The following is a description of a gene set: Human Gene Set: GOCC_CYTOPLASMIC_MICROTUBULE studied in species Homo sapiens Any microtubule in the cytoplasm of a cell., and this is the list of marker genes: CFAP52, ENKD1, TMEM214, CYP2A6, CYLD, RIBC1, TRPV4, PACRG, CFAP68, CFAP161, APC2, TUBG1, ARHGAP18, EFCAB6, TOGARAM1, MAP9, CIMIP2A, TEKT1, HID1, BIRC5 (NCBI Gene Id 332), IFT70A, KIF2C, ARFGEF2, CLMP, CFAP141, SPAG8, CFAP90, GTSE1, DYNLT1, FHDC1, TUBA1C, CFAP77, REEP1, EFHB, ARL6, IFT70B, SAXO2, MISP, TEKT2, SERP1, SRPRB, RAB3D, EFHC2, TUBA1A, TOGARAM2, SYBU, BCAS3, TEKTL1, CIMIP2C, MAPRE3, MTUS2, CFAP126, TUBB4B, SPMIP6, CFAP53, CEP162, BCL10, SCTR, TEKT5, SAXO4, SPMIP9, DYNLT3, REEP2, CCSAP, SNPH, TEKT3, CLASP1, DYNC1H1, CFAP276, NUMA1, CFAP95, CFAP20, KIF18B, DUSP21, PIERCE2, MAPRE1, SELENOS, TUBGCP2, KIF18A (NCBI Gene Id 81930), NME7, SPMIP10, ARL3 (NCBI Gene Id 403), MNS1, PIERCE1, MID1, REEP4, CFAP96, SPACA9, APC, EFHC1, FAM161B, TUBG2, TEKTIP1, CFAP144, MAP10 (NCBI Gene Id 54627), TEKT4, SAA1, CIMAP1D, DCXR, BICD1, FAM161A, ENKUR, REEP3, RIBC2, CLASP2, TPT1, SAXO1, CFAP45, PAFAH1B1 (platelet activating factor acetylhydrolase 1b regulatory subunit 1), GRAMD2B, CFAP107, TUBA1B, FBXW11, NIN, CFAP210, PDE4DIP, CFAP206, SPMIP8, CIMIP2B, MAPRE2, SPMIP11